Given this list of marker genes Slfn14, Atp13a2, Atf4, Lrrk2, A3galt2, Bace1, Eif2s1, Th, Ireb2, here is a description of the gene set: Any process that results in a change in state or activity of a cell (in terms of movement, secretion, enzyme production, gene expression, etc.) as a result of a manganese ion stimulus. Mouse Gene Set: GOBP_CELLULAR_RESPONSE_TO_MANGANESE_ION species: Mus musculus